Given this list of marker genes PRKAA1, ERLEC1, STT3A, PSMA7, SPOP, JAK1, PSMD7, ERLIN2, PSMD2, PSMA1, NEK2, RBX1, DAD1 (NCBI Gene Id 1603), PSMA2, CSNK2A1, OS9, BTRC, DDOST, PRKAG2, PSMB2, CCND1, PDCD1, PSMD11, PSMC1, PSMB5, MIB2 (MIB E3 ubiquitin protein ligase 2), PSMD8, GSK3B, CUL3, COPS5, PSMD13, OSTC, PRKAA2, VCP, RPN2, RNF185, PSMD6, PSMB6, RPS27A, PSMB1, PSMD1, ADRM1 (ADRM1 26S proteasome ubiquitin receptor), MAGT1, PSMD14, PSMC4, OST4, CDK4, PSMA4, TUSC3, B3GNT3, PSMB7, PRKAG3 (NCBI Gene Id 53632), PSMC2, CSNK2A2, PSMD12, PRKAB2, PRKAG1, TMEM258, DERL3, PSMC5, SEL1L, PSMA5, PSMC3, DERL1, UBC, ERLIN1, CSNK2B, SEM1, RNF5, PSMB3, YWHAG, PRKAB1, STT3B, PSMA6, SKP1, UBA52, PSMD3, PSMA3 (proteasome 20S subunit alpha 3), PSMC6 (NCBI Gene Id 63380), CUL1, UBB, RPN1, DERL2, CD274, PSMB4, PDCD1LG2, here is a description of the gene set: Post-translational modification (PTM) of CD274 (PD-L1) is a crucial regulatory mechanism that significantly impacts its stability, surface presentation and interaction with its receptor PD-1, thus modulating normal immune function and immune response in cancers by influencing tumor immune evasion. PTMs of PD-L1 includes glycosylation, ubiquitination/de-ubiquitination, phosphorylation. These post-translational modifications collectively modulate the effectiveness of PD-L1 in immune checkpoint pathways and have significant implications for the development of immune therapies targeting PD-L1 in various diseases, including cancer. These processes reveal potential therapeutic targets for enhancing the efficacy of PD-L1 inhibitors by manipulating its post-translational regulation (Ming et al.,2021, Yamaguchi et al.,2022) studied in species Homo sapiens Reactome Pathway: Regulation of PD-L1(CD274) Post-translational modification part of: Regulation of PD-L1(CD274) expression